Given this list of marker genes MAEL (NCBI Gene Id 84944), DDX4 (DEAD-box helicase 4), TDRD9, ANKRD34A, PIWIL1, HELZ2, HELZ, ANKRD34C, PIWIL4, TDRKH, DDX3Y (NCBI Gene Id 8653), ANKRD34B, EXD1, DDX3X, PIWIL2, TDRD1, TDRD6, MOV10, SNRPGP15, TDRD7, CARHSP1, PIWIL3, HENMT1, MOV10L1, GTSF1, ASZ1, SNRPG, TDRD5 (NCBI Gene Id 163589), here is a description of the gene set: Human Gene Set: GOCC_POLE_PLASM studied in species Homo sapiens Differentiated cytoplasm associated with a pole (animal, vegetal, anterior, or posterior) of an oocyte, egg or early embryo.